The following is a description of a gene set: IFNs are highly pleiotropic cytokines also endowed with marked anti-angiogenic activity. In this study, the mRNA expression profiles of endothelial cells (EC) exposed in vitro to IFN-alpha, IFN-beta, or IFN-gamma were determined. We found that in HUVEC as well as in other EC types genes were upregulated (>2-fold increase) by IFNs, including genes involved in the host response to RNA viruses, inflammation, and apoptosis. Interestingly, genes showed a >5-fold higher induction by IFN-alpha in EC compared to human fibroblasts; among them, the gene encoding the angiostatic chemokine CXCL11 was selectively induced by IFN-alpha in EC along with other genes associated with angiogenesis regulation, including CXCL10, TRAIL, and guanylate binding protein 1 (GBP-1). These transcriptional changes were confirmed and extended by quantitative PCR analysis and ELISA; whereas IFN-alpha and IFN-beta exerted virtually identical effects on transcriptome modulation, a differential gene regulation by type I and type II IFN emerged, especially as far as quantitative aspects were concerned. In vivo, IFN-alpha-producing tumors over-expressed murine CXCL10-11, GBP-1 and TRAIL, with evidence of CXCL11 production by tumor-associated EC. Overall, these findings improve our understanding of the anti-angiogenic effects of IFNs by showing that these cytokines trigger an anti-angiogenic transcriptional program in EC. Moreover, we suggest that quantitative differences in the magnitude of the transcriptional activation of IFNresponsive genes could form the basis for cell-specific transcriptional signatures. from publication Indraccolo S, Pfeffer U, Minuzzo S, Esposito G, Roni V, Mandruzzato S, Ferrari N, Anfosso L, Dell'Eva R, Noonan DM, Chieco-Bianchi L, Albini A, Amadori A (PMID 17202376) Genes up-regulated in endothelial cells: interferon alpha versus IFNG. species: Homo sapiens Human Gene Set: GSE3920_IFNA_VS_IFNG_TREATED_ENDOTHELIAL_CELL_UP, and this is the list of marker genes: PRKAB2, TRAF1, SBDS, FAP, SET, VPS37B, OTULIN, TNFAIP3, YTHDC1, WNK1, SIK1, CCNL2, CLK4, CHKA, FAM118A, HNRNPH1, PITPNM1, UHRF2, CATSPERD, SPAG9, IMPACT, FAM133B, DNAJB2, MAFF, PLK3, SERTAD1, VEGFA, PAF1, SAMD8, MTHFR, GAS5, WSB1, EIF5, KLF4, LINC-PINT (NCBI Gene Id 648716), TRIM39, ISY1, TTC19, SLC7A6OS, PTPN23, TGIF1, CDC37L1, NLGN3, ADRB2, NUFIP2, MBTD1, EGR1, FRG2B, CCDC9, TOR1AIP2, IFIT1, GPR4, NKRF, SLC35E2A, BAIAP2, ZC3H12A, RELB, CXCL10, STX5, KCNIP2, ARL13B, STAR, CSRNP1, ATXN7, ATF3, MXD1, SAFB2, SLC3A2, DUSP8, DNAJC5, POLG2, AGO3, SLC5A3, DNAI7, FBRSL1, SMAD7, FRYL, BTG2 (BTG anti-proliferation factor 2), RAB3GAP1, TMEM54, PRAM1, KDM5A, FNBP4, TAGAP, BAG3, SARAF, TAGLN, EIF4A2, RND1, NUP210L, PDE4A, CD274, SUCO, TNFRSF18, PYGM, CSRNP2, NR4A3, LMBR1L, AKAP13, LUC7L3, ZC3HAV1, PSD, FGD3, EPHX3 (NCBI Gene Id 79852), JMY, NR4A2, FOSL2, ELL2, GCA, KCNG3, TRA2A, CREM, ZFAND2A, HNRNPDL, CTSL, TUT7, DHX40, CRY1, CNBP, CLK1, TBX6, DUSP10 (NCBI Gene Id 11221), SLC25A25, PDCD1LG2, KDM6B, LAX1, ANKDD1A, TNFRSF10B, ATG16L2, LMAN1L, DUSP16, PPP1R10, DNAJA4, CCNL1, AFG2A, NR1D2, SF3B1, DOT1L, RMRP, KATNA1, NFKBID, TINF2, FNIP1, AOC2, ZUP1, MIR202, DDX5, ENKUR, SLC38A2 (NCBI Gene Id 95454), SON, TMEM63B, HOMER1, REL, ERICH6 (NCBI Gene Id 131831), SKIL, DDX3Y, CABYR, CWC25, ERF, ARL5B, RBM15, CDK11B, GCH1, CPEB2, CHD2, PCF11, THBS3, VAMP2, TASOR2 (NCBI Gene Id 54906), NR4A1